The following is a description of a gene set: Human Gene Set: FAN_EMBRYONIC_CTX_IN_6_INTERNEURON species: Homo sapiens from publication Fan X, Dong J, Zhong S, Wei Y, Wu Q, Yan L, Yong J, Sun L, Wang X, Zhao Y, Wang W, Yan J, Wang X, Qiao J, Tang F (PMID 29867213), and this is the list of marker genes: DLX6-AS1, BTG1, HSPA1A, DLX1, TMEM161B-DT, SCGN